The following is a description of a gene set: from publication Fu W, Ergun A, Lu T, Hill JA, Haxhinasto S, Fassett MS, Gazit R, Adoro S, Glimcher L, Chan S, Kastner P, Rossi D, Collins JJ, Mathis D, Benoist C (PMID 22961053) Human Gene Set: GSE40274_CTRL_VS_LEF1_TRANSDUCED_ACTIVATED_CD4_TCELL_UP The transcription factor FoxP3 partakes dominantly in the specification and function of FoxP3+ CD4+ T regulatory cells (Tregs), but is neither strictly necessary nor sufficient to determine the characteristic Treg transcriptional signature. Computational network inference and experimental testing assessed the contribution of several other transcription factors (TFs). Enforced expression of Helios or Xbp1 elicited specific signatures, but Eos, Irf4, Satb1, Lef1 and Gata1 elicited exactly the same outcome, synergizing with FoxP3 to activate most of the Treg signature, including key TFs, and enhancing FoxP3 occupancy at its genomic targets. Conversely, the Treg signature was robust to inactivation of any single cofactor. A redundant genetic switch thus locks-in the Treg phenotype, a model which accounts for several aspects of Treg physiology, differentiation and stability. Genes up-regulated in CD4 T conv: control versus over-expression of LEF1. studied in species Homo sapiens, and this is the list of marker genes: RNF141, FAM117A, GAB2, THEMIS2, PDGFC, FGL2, FRMD4A, PTMS, FMO5, CD99L2, DOCK8 (NCBI Gene Id 81704), KLRC1, BARD1, RNASEL, GSAP, ATP6AP1, SEC14L1, LPP, MALT1, AP1S2, ALDOC, RTL5, DNAI4, SLC25A23, ASAH1, LRRC56, H2AC15, N4BP2L1, PQBP1, BIN2, RSU1, INPPL1, SLC28A2, PLCB2, APOBEC1, NCR1, RFC2, MAN2A1, ARHGAP9, FAM161A, STEAP4, ROGDI, STYK1, CFH, PROS1, TTC9C, FAM110A, TCN2, UNC5CL, NPL, APOC2, DRD5, CAP1, FCGR1A, XKRX (NCBI Gene Id 402415), ADGRE5, MYO18A, CACNB4, HCLS1, IQCE, POLD1, JAG1, TCP11L1, DAB2, MYL12B, GAPT, SYNE2, DOCK11, ARL11, PI16, OSBPL5, COBLL1, PXMP4, PRCP, SH3BGRL3, STK10, PLEKHM1, PPP1R9A, CD81, EZR, HDAC7, ZZEF1, CD302, CST3, SMARCA2, SLC2A3, RAB36, SEC24D, SPNS3, MID1IP1, RNF181, GYPA, RCSD1 (NCBI Gene Id 92241), FSIP1, CHCHD10, PTPN14, BCL6, PDLIM2, GLRX, GRHPR, TRMT2B, CEBPA, RAB32, ATF7IP, RPRM, TMEM229B, MPZL1, TLR3, LAPTM5, XDH, ZEB2, VWA5A, C1QTNF12, EMID1, SCAMP1, PPP3CC, MAP3K1, AURKB, PIP4K2A, EDEM2, ACSF2, EVI5L, CD8A, WDR6, SLC45A2, MYL4, ARL6IP1, TPCN1, MINK1, CTBP2, KCNJ16, FBLIM1, CD24, CASP9, NKG7, TMBIM6, PXK, TAX1BP3 (Tax1 binding protein 3), PLCL1, FAM168A, CTDSPL, TMEM106A, ANKRD13D, CDC42SE2, SERINC3, FCRL1, ENPP1, NDST1, ST3GAL4, RIN2, ERP27, PPARG, KHK, UBE2R2, HES1, CD200 (NCBI Gene Id 4345), FMNL2, CKAP4, CTSC, HIGD2A, RASGRP3, MAGED1, MATK, CD300LB, STC1, ILK, TMPO, STARD9, CPEB2, IRGC, SPO11, NCF2